The following is a description of a gene set: Human Gene Set: MIR873_5P Genes predicted to be targets of miRBase v22 microRNA hsa-miR-873-5p in miRDB v6.0 with MirTarget v4 prediction scores > 80 (high confidence targets). from publication Chen Y, Wang X (PMID 31504780) species: Homo sapiens, and this is the list of marker genes: ANKRD27, SPOCK1, JCAD, CCN5, FOXK2, ATP8B2, PHF6, E2F7, SEH1L, PCSK5, GTF2H1, GPATCH2L, SH3RF1, PRKAA1, PER3, TERF1, MED1, PSG3, IDS, EPC1, PGM2L1, GRIK2, SNX27, CACNB2, STRBP, SYN3, HNRNPM, MROH9, ENAH, CEACAM8, HR, ATP6V1G1 (ATPase H+ transporting V1 subunit G1), DHRS12, BTBD9, CEMIP2, PGK1, PECAM1, CSGALNACT2, DNAJC18, GALNT1, BPGM, CDK15, EPB41L4B, HMOX1, CHRNA5, SRRM2, ARGLU1, LIX1L, ARHGEF11, MRTFA, FAM83A, BCL7A, CLEC17A, NPTN, ZDHHC15, TRAPPC14, TUSC3, HNRNPDL, BSCL2, ZNF805, DPF2, ZSWIM5, NOTCH2NLA, SPRY3, ATP2B1, TNRC6B, STRA6, PSG5, PPP4R1, EPB41L5, SPRED3, PHIP, PADI2, ZNF385B, PTGS1, PSD3, ITIH6, EGLN3, COX6C, GPRASP1, HCLS1, LYPD1, ZNF608, TUBGCP3, YAF2, SERTAD2, KPNA1, PDE4D, KLHL11, GCH1, S100A7A, AFAP1L2, RBFOX2, ENDOV (endonuclease V), PSG11, MLXIPL, RNASEH2B, ZSCAN32, NKAIN3, IGSF11 (NCBI Gene Id 152404), ABCE1, CNNM4, MED9, PTPN12, AHNAK, CTBS, KRT20, ITGB6, HPCAL4, TMEM266, MCM9, MAP4K3, CCDC60, DSG2, THUMPD1, ABCA1